The following is a description of a gene set: Mouse Gene Set: GOMF_HISTONE_DEACETYLASE_REGULATOR_ACTIVITY species: Mus musculus Binds to and modulates the activity of histone deacetylase., and this is the list of marker genes: Mapk8, Ing2, Trp53, Hopx (HOP homeobox), Ski, Ncor1, Ucn, Sirt6